Given this list of marker genes Pex10, H2bc6, Cdc73, Ube2b, H2bc24, Pex5, Pex14, H2bc23, H2bc21, Pcna, Rnf152, Rraga, H2bc14, H2bc7, Wac, H2bc12, Bcl10, Ube2a, H2bc9, Pex2, Hltf, Rps27a, Uba52, Ube2e1, Rnf181, Ube2n, Ube2d1, H2bc4, Rnf144a, Ubb, Ctr9, Ubc, H2bc15, Leo1, Rnf40, Ube2d3, Pex13, Rad18, H2bc8, Ube2l3, H2bc1, Ube2v2, Skic8, Rnf20, Prkdc, Shprh, Pex12, Ube2d2a, Paf1, H2bc3, H2bc22 (NCBI Gene Id 319188), H2bc13, H2bc11, Uba52rt, here is a description of the gene set: Mouse Gene Set: REACTOME_E3_UBIQUITIN_LIGASES_UBIQUITINATE_TARGET_PROTEINS E3 ubiquitin ligases ubiquitinate target proteins species: Mus musculus